Given this list of marker genes WNK1, BNIP3, DMD, HLA-DRB3, PURA, SBNO1, INTS7, ALCAM, PARP16, KLHL15, SLC25A22, NRAS, MIOS, PPP4R3B, PKD1, THOC7, NOX4, ARL8B, AEN, PTGDR2, GLCCI1, LIPA, MED14, UBR7, WDR75, USP25, CD164, RBBP6, PUM2, DBF4, KBTBD8, RAB8B, PIP5K1A, TAF1D, GTPBP1, CRKL, PPTC7, APOA2, EIF2AK3, NUP205, SUDS3, RLF, STK10, STK4, NSUN2, NFYA (nuclear transcription factor Y subunit alpha), RNGTT, DNAJC5B, HOXA7, C1orf159, WSB1, TACC1, SH3TC1, LBR, KLRA1P, DDX49, SP1, KLF10, SEC16A, TUG1 (NCBI Gene Id 55000), FEM1A (NCBI Gene Id 91037), FYTTD1, PMAIP1, STARD4, DNAJA3, SCYL2, SMC5, AKR1D1, TAGAP, SNRNP200, DCLRE1C, ZHX2, BET1L, VPS35L, CREBZF, DNA2, CRIP2, AGO2, PIBF1, NFATC1, OPA1, NCOR1, SH3BGRL (NCBI Gene Id 96022), EAF1, C2CD5, ANKRD20A1, MUS81, A1CF, MDM2, G3BP2, PELI1, DHX15, PRKCI, NMD3, PTPN11, SGCD, BRAF, SEC24C, here is a description of the gene set: studied in species Homo sapiens Human Gene Set: MODULE_97 Genes in the cancer module 97.